Given this list of marker genes CSPG5, GABRA3, MKLN1 (muskelin 1), CNTN5, SLC32A1, SST, SEMA7A, GRID1, GABRR2, GABRR1, SLITRK3, ENAH, KCNC2, CNR1, PIK3C3, PRAF2, KCND3 (potassium voltage-gated channel subfamily D member 3), SEMA4D, DRD2, CACNA2D2, C1QBP, KCND2, GABRA4, CTBP1, BSN, EFNA5, NXPH4, CBLN4, TRPV1, GABRG2, DRD1, GABRA5, KIF5C, INSYN1, LAMP5, NPY, LRFN5, SLC6A1, GABRA2, GABARAP, GABRD, FLOT1, RPS6, NRXN1, GUCY1A1, BAIAP3, SLC6A11, SUMO2, ERC2, SLC4A10, NLGN4Y, GPHN, AP3M2, GABRG3, LHFPL4, PLCB1, GIT1, SH3KBP1, CACNA2D1, GLRB, CACNA2D3, SHROOM4 (NCBI Gene Id 57477), SLC6A17, ABHD6 (abhydrolase domain containing 6, acylglycerol lipase), NXPH1, CLCN3, CALB1, NLGN2, ATP2B3, CDH13, NSF, ATP2B2, NLGN1, SV2A (synaptic vesicle glycoprotein 2A), STRN4, DAG1, LRFN4, SLITRK1, LPAR1, RPS27, GABRA1, GABBR1, GABRB1, GAD1, DISC1, ARFGEF2, GABRB2, PTPRO, ADRA2A, FGF7, ARHGEF9 (NCBI Gene Id 23229), GNAO1, SLITRK2, IQSEC3, MDGA1, NLGN3, SLC6A6, GLRA2, ERBB4, GABRB3, GAP43, PCDH17 (protocadherin 17), NLGN4X, NPY5R, FGF22, GABRR3, LRRTM1, CNTNAP2, FUS, ZDHHC5, CDH10, CNRIP1, PCLO, LRRTM2, CLSTN3, here is a description of the gene set: A synapse that uses GABA as a neurotransmitter. These synapses are typically inhibitory. Human Gene Set: GOCC_GABA_ERGIC_SYNAPSE studied in species Homo sapiens